The following is a description of a gene set: species: Homo sapiens from publication Chen Y, Wang X (PMID 31504780) Genes predicted to be targets of miRBase v22 microRNA hsa-miR-5579-3p in miRDB v6.0 with MirTarget v4 prediction scores > 80 (high confidence targets). Human Gene Set: MIR5579_3P, and this is the list of marker genes: CREBRF (CREB3 regulatory factor), PDIK1L, NCAPG, HNRNPU, DAZ4, PRKCE, BBS12, EML6, RAPGEF6, SFT2D1, GLIS2, FCGBP, SCN8A (sodium voltage-gated channel alpha subunit 8), TENT4B, IL12A, RP2, PELI1, HBP1, PRDX3, ADGRE5, HEATR5A, NOVA1, PLEKHA1 (NCBI Gene Id 59338), PLAG1 (NCBI Gene Id 7996), DAZL, HIPK3 (homeodomain interacting protein kinase 3, NCBI Gene Id 10114), EXO1, PIGN, GPR34, TRPA1, RBM17, TRIM33, CDC25A, CCNYL1, SESN1, GRAMD2B, SKI, MOXD1, POM121, PIKFYVE, RFX3, HERC4, MGAT5, JAG1, ZSWIM6, MSX1, MAPRE1, ETNK1, DAZ3, KDM7A, ZBTB41, CEACAM8, GABRB2, UNC80, PDCD4, DCAF7, PBRM1, IPO11, GLRA2, HPS5, GATAD2B, RAB11FIP2, CLIC5, FBXO28, ALDH9A1, MTM1, ABCD2 (ATP binding cassette subfamily D member 2), KLF5, CCDC34, RMND5A, CEP57L1, SCML2, HSD17B7, ATRN, PPP1R3D, TGFBI, MOSMO, RALGPS2, BCL11A, CSRNP3, LSM3, ADAMTS3, MAST4, PHLDA1, PPP3CA, HOMER1, RNF217, FBXL17, DAZ2 (NCBI Gene Id 57055), AP3M1, CFL2, CPEB3, GAREM1 (NCBI Gene Id 64762), TRMT6, GIMAP5, SLC22A15, SOX7, SERPINI1, DIPK2A, PRXL2A, NKIRAS1, TRMT5, USO1, IL6R, MCTP1, RECK, ADNP (activity dependent neuroprotector homeobox), SLC7A6 (NCBI Gene Id 9057), IFFO2, BICC1, DAZ1, KLF3 (NCBI Gene Id 51274), CDH7, FAM168B, GIMAP1-GIMAP5, BTG2, CD36, ITGB8, PURA, FANCC, GID4, CTNND2, ZDHHC17, FHIP2A, RAB1A, STAG2, RBMS3, LRRN1, MALT1, UBE2K, CMBL, BCL11B, ANKRD33B, CEACAM5, HOOK3, DCUN1D3, LRRC57, CFAP300, MIA3, SKP2, ZNF367, PDE6A, ELF2, IRAK1BP1, RASGRP1, UBE2D3, TNS1, CCL20, KBTBD8, MACO1, BBS9, ASF1A, EGR3 (NCBI Gene Id 1960), RIMBP2, YOD1, SPRY2, FASLG, NRL, CSN1S1, ADGRG2